Given this list of marker genes Snhg14, C820005J03Rik, Mbp, Ighg2b, 2900092N22Rik, Glce, Kcne4, Tnfrsf9, Fam110b, 9630013A20Rik, Gm5129, Agbl4, E230016K23Rik, Map7, Pcyox1l, Spic, Dhcr24, Reg3g, Penk, Col10a1, 2700038G22Rik, Rerg, Bdkrb2, Gdf10 (NCBI Gene Id 14560), Dmp1, Pthlh, Mei4, Myb, Glod5, Cage1, Ret, Ccr9, Igkc, Hspa1a, Reln, Radil, Pcsk5, 4930447C04Rik, Gm29761, Trim30d, Tmem100, Bst1, Bmp7, Add2, Lca5, Rps15a-ps6, Shisal2b, Tcaim, Gpr174, 4931400O07Rik, Bche, G6pdx, Scara5, Adam18, Trpc3, A530021J07Rik, Nme7, Slc1a3, Tma16, Thsd4, Scg5, Ttc39b, Slc29a2, Ccl22, Spon1, Elavl1, Zfp93, Relch, Arrdc4, Aqr, Dusp5, Elapor1, Stk33, Gria2, Mfsd3, Mcpt1, Abhd8, Atp1a4, Tspan32, Wif1, Serpinb5, Arhgef12, C1qtnf7 (NCBI Gene Id 78661), Ctdsp2, Slc25a4, Mfsd4a, Ptprs, Ptger3, Tmem107, 4933416E14Rik, Tecpr1, Hnf4g, Wnt9b, Hemgn, Brwd3, Sfswap, Ms4a1, Slc26a3, Reg1 (NCBI Gene Id 19692), Cpsf2, Tnmd, Vmn1r30, Ice2, Sh2d4b, Nog, Rbpjl, Spata9, Gzmg (granzyme G), Zfp68, Mpzl2, Mir23a, Sumf2, Spock1, Srgap2, Hsd11b1 (hydroxysteroid 11-beta dehydrogenase 1), Foxd1 (NCBI Gene Id 268693), Frzb, Slc28a3, Sfrp1, Nebl (nebulette), Dmc1, Clec2g (NCBI Gene Id 70809), Nmnat1, Adamtsl5, Tspan11, Ptch1, Gigyf2, Epha3, Kng1, Gzmf, Rab22a, Coa8 (cytochrome c oxidase assembly factor 8), 4933411E06Rik, Dusp15, Aldh1a3, Bcas3, Tram2, Scn2a, Masp1, Slco4a1, Cadm2, Dph2, Ntrk2, Igfbp5, Nsg1, Gm4924, Tcstv3, Zc3h13, Cripto, Gm36839, Trpc1, Serpina7, 2010320M18Rik, Lepr, Ddx23 (DEAD box helicase 23), Irs3, Tnfrsf19, St8sia2 (ST8 alpha-N-acetyl-neuraminide alpha-2,8-sialyltransferase 2), L1td1, Prtn3, Alas2, Galr2, Zfp2, Brinp3, Rdh10, Gli2, Il11, 1700110C19Rik, Ric3, here is a description of the gene set: Mouse Gene Set: YAUCH_HEDGEHOG_SIGNALING_PARACRINE_UP Ligand-dependent activation of the hedgehog (Hh) signalling pathway has been associated with tumorigenesis in a number of human tissues. Here we show that, although previous reports have described a cell-autonomous role for Hh signalling in these tumours, Hh ligands fail to activate signalling in tumour epithelial cells. In contrast, our data support ligand-dependent activation of the Hh pathway in the stromal microenvironment. Specific inhibition of Hh signalling using small molecule inhibitors, a neutralizing anti-Hh antibody or genetic deletion of smoothened (Smo) in the mouse stroma results in growth inhibition in xenograft tumour models. Taken together, these studies demonstrate a paracrine requirement for Hh ligand signalling in the tumorigenesis of Hh-expressing cancers and have important implications for the development of Hh pathway antagonists in cancer. Genes up-regulated in mouse stroma of pancreatic adenocarcinoma zenografts after treatment with HhAntag, a hedgehog (Hh) pathway inhibitor. from publication Yauch RL, Gould SE, Scales SJ, Tang T, Tian H, Ahn CP, Marshall D, Fu L, Januario T, Kallop D, Nannini-Pepe M, Kotkow K, Marsters JC, Rubin LL, de Sauvage FJ (PMID 18754008) studied in species Mus musculus